The following is a description of a gene set: Cleft lip A gap in the lip or lips. studied in species Homo sapiens Human Gene Set: HP_CLEFT_LIP, and this is the list of marker genes: NBN, MASP1, BRD4, RPL9, NSD2, MEIS2, GFRA1, COLEC10, SMOC1, RPL35 (ribosomal protein L35), SF3B4, FKTN, DYNC2LI1, TAPT1, RAI1, SPOP, HOXD13, RPS24, SMC1A, POMT2, MED12, FZD2, RPL27, ACTB, COLEC11, DLG5, TRRAP, MEOX1, CPLANE1, IFT80, NSMF, FGFR1, RPS20, RPL15, DSE, NSDHL, GRHL3, ALX4, CCDC32, MTHFR, EVC, LETM1, TRAPPC9, GLI3, PAX3, ARHGAP31, SUMO1, SNRPB, FILIP1, ANKRD17, RPS27, ESCO2, IQSEC2, RPS15A, MSX2, PROKR2, RIPK4, CILK1, CDH1, KANSL1, PHF8 (PHD finger protein 8), RET, GAS1, RSPO2, RIC1, MYL11, RPL31, RPL5, AMER1, ADA2, SPECC1L, B3GLCT, RPL35A, CHD7, NUP107, RPS7, SF3B2, WLS, DLL1, FREM2, RAB5IF, WNT3, SMPD4, STAG2, C2CD3, NODAL, NELFA, OFD1, DVL3, SMCHD1, IRF6, POMT1, FLII, FOXH1, EIF2S3, FGD1, TGIF1, FLNB, PIGL, LARGE1, NUAK2, TFE3, DHODH, EFNB1, RAB34, RERE, SHH, RPL18, JUP, FGF8, SIX3, GRIP1, INTS1, ZIC2, DDX3X (NCBI Gene Id 730543), WNT9B, NECTIN1, PORCN, DDX59, NEK1, RPS10, TBX2, YAP1, PHGDH, RPS17, POLR1A, ZSWIM6, ASXL1, POLR1D, NIPBL, FGFRL1, TSR2, GDF11, CYP26C1, SEMA3E, KIF7, FGF20, RPL26, CRIPTO, LMX1B, PIGG, OCLN, CDON, EVC2, HEATR3 (HEAT repeat containing 3), WDR35 (WD repeat domain 35), JARID2, SMO, MKS1, KAT5, IFT57, VAX1, DLX4, FRAS1, TP63, UBB (ubiquitin B), PIGN, TGDS, TCOF1, MID1, KMT2D, TCTN2, VANGL2, TFAP2A, DYNC2H1, GREB1L, GATA1, FOXC2, RPS28, MSX1, DYNC2I1, FBXO11, TBX4, GPC4, FKRP, RPL11, PTCH1, TMCO1, PIGV, EPG5, POLR1C, BCOR, CC2D2A, H4C3, STIL, RPS19, GPC3, RPGRIP1L, RPS29, CTNND1, INTU, FLRT3, PPP1R13L, PLCH1, DISP1, DEAF1, FOXF1, CTBP1, TCTN3, ITGA8, GLI2, CPLX1, POLR1B, TXNL4A, HYLS1, NAA10, DYNC2I2, RPL8, RPS26, GJA1, CCN2, WNT4, KDM6A, CHUK, CEP120, CHST14, KATNIP, SLC29A3, BMP4, ALX3, SMAD4, SMG9 (NCBI Gene Id 56006)